Given this list of marker genes PTH1R, FANCG, DNAAF2, SMARCAD1, TERT, FANCD2, DNAI1, RSPH3, POT1, DNAH11, ACVRL1, NCKAP1L, KRT9, HYDIN, SLC34A2, IL21, HSPG2, SCNN1G, PARN, MARS1, DRC1, FLNB, IL6ST, NME8, LRBA, STK11, BRCA1, RTEL1, BRIP1, DPP9, ODAD3, SMARCA2, PTEN, CCDC39 (coiled-coil domain 39 molecular ruler complex subunit), DNAJB13, SFTPC, FOXJ1, PALB2, GTF2H5, CFTR, KRT1, JAG1, HPGD, SFTPA1, SMAD4, NLRP3, FANCA, DNAH5, FANCC, PIGL, MPLKIP, RAD51C, TCF4, DNAAF3, ABCA12, CFAP221, ODAD4, FANCE, RSPH9, CD55, EIF2AK4, PSMB8, MUC5B, RASGRP1, MCIDAS, RHBDF2 (rhomboid 5 homolog 2), TERC, ZFX, SFTPA2, SLX4, FANCB, FCGR2A, GJB6, ODAD2, STK36, FANCI, RFWD3, DSP, FANCM (NCBI Gene Id 57697), ODAD1, KRT10, ENG, LIFR, DNAAF5 (dynein axonemal assembly factor 5), BTNL2, SPEF2, CFAP300, SCNN1B, CARS1, CCNO, ATP11A, DNAAF1, GAS2L2, TARS1, NEK10, RPGR, GTF2E2, ABCA3, MAD2L2 (mitotic arrest deficient 2 like 2), RAD51, FAM13A, UBE2T, DNAAF11, CCDC40 (coiled-coil domain 40 molecular ruler complex subunit), FANCF, SCNN1A, SLC5A6, CFAP74, VPS51, ERCC3, ZMYND10, SLCO2A1, OFD1, INTU, XRCC2, KRT16 (NCBI Gene Id 3868), DNAH9, AARS1, SPAG1, RSPH4A, IRF1, BRCA2, POLA1, DNAI2, VPS33A, PRKACB, DNAAF6, CDC45, RNF113A, TGFB1, NME5, STN1 (NCBI Gene Id 79991), HNRNPH1 (NCBI Gene Id 3187), BMPR1A, ERCC2 (NCBI Gene Id 7269), LRRC56, TLL1, SFTPB, DNAL1 (NCBI Gene Id 83544), ERCC4, TTC12, DNAH1, FANCL (FA complementation group L), HLA-DRB1, MALT1, RSPH1, RNF31, DNAAF4, UBE2A, CFAP298, here is a description of the gene set: Broadening of the soft tissues (non-edematous swelling of soft tissues) of the digital tips in all dimensions associated with an increased longitudinal and lateral curvature of the nails. Clubbing Human Gene Set: HP_CLUBBING studied in species Homo sapiens